Given this list of marker genes F3, HSPA1B, ELANE, F2RL1, ZNF580, TLR4, LAMTOR5, RIGI, LEP, APOA2, CD58, IL17D, IL6, NOD2, LBP, HMGB1, TLR7, TLR9, CAMP, RELA, TNF, DEFA5, MYD88, CD14 (CD14 molecule), TLR2, GDF2, TLR8, PRG3, FCN1, LILRA2, TLR1, ADIPOQ, CD2, CALCA, AFAP1L2, CHI3L1, PRKD2, TLR3, LGALS9, HSPA1A, IL1B, SERPINE1, PYCARD, FADD, SYK, CLEC7A, BCL10, STAT3, PARK7, NLRP10 (NLR family pyrin domain containing 10), NOS2, NOD1, RAB1A, TLR5, FFAR2, TIRAP, PLA2G1B, CD244, F2R, WNT5A, HYAL2, CD74, DDIT3, MAVS, RIPK1, here is a description of the gene set: Any process that activates or increases the frequency, rate, or extent of interleukin-8 production. Human Gene Set: GOBP_POSITIVE_REGULATION_OF_INTERLEUKIN_8_PRODUCTION studied in species Homo sapiens